The following is a description of a gene set: Human Gene Set: GOBP_CELLULAR_RESPONSE_TO_ESTROGEN_STIMULUS Any process that results in a change in state or activity of a cell (in terms of movement, secretion, enzyme production, gene expression, etc.) as a result of stimulus by an estrogen, C18 steroid hormones that can stimulate the development of female sexual characteristics. species: Homo sapiens, and this is the list of marker genes: TRIM24, MDM2, AR, BCAS3, PELP1, SFR1, CRHBP, ESR1, SERPINB9, MIR493, CDK12, ARID5A, RARA, NCOA4, WBP2, CLDN18, SP1, OCSTAMP, SFRP1